Given this list of marker genes Slc5a5, Clca3b, Clcnkb, Ano8, Gabrd, Slc5a6, Gabrq, Apol10a (apolipoprotein L 10A), Chrm5, Slc25a25, Best3, Slc4a3, Slc26a10, Gabre, Clca3a1, Ano7 (NCBI Gene Id 404545), Mfsd5 (major facilitator superfamily domain containing 5), Gabrg2, Slc37a4, Gabrb1, Stx7, Clcn5, Slc6a18, Slc25a10, Slc4a10, Gabrr2, Slc22a3, Ttyh2, Slc1a7, Slc25a3, Gabra3, Ano4, Slc25a30, Slc4a1, Clic6, Glrb, Clic3, Cftr, Ano10, Slc26a1, Slc12a6, Gabrb3, Slc25a14, Best1, Slc12a7, Gabrg3, Trpv1, Slc12a4, Glra3, Ano9, Ano1, Slc4a5, Slc4a2, Cldn4, Slc6a6, Slc26a7, Gabrr1, Gabra4, Clic4, Slc26a9, Slc12a1 (solute carrier family 12, member 1), Tmc4, Gabrr3, Slc17a8, Slc25a27, Ano2, Chrna7, Vti1b, Slc26a8, Slc13a1, Slc6a13, Gabrp, Mfsd8, Gabrb2, Clca4a, Glra2, Slc37a1, Slc22a6, Vamp8, Slc25a24, Apol11a, Slc13a4, Slc17a1, Slc26a6, Slc1a4, Pacc1, Slc17a7, Clca3a2, Gabra2, Nherf1, Slc6a2, Stx1a, Clcn4, Slc4a4, Ano5, Ttyh1, Slc26a3, Ucp2, Ano6, Clca2, Apol8, Slc6a11, Slc12a3, Gabra6, Clcn3, Slc26a11, Slc4a11, Slc6a8 (solute carrier family 6 (neurotransmitter transporter, creatine), member 8), Nmur2 (NCBI Gene Id 216749), Slc6a12, Slc4a8, Slc34a1, Bsnd, Clic5, Slc25a23, Slc26a5, Slc34a2, Clcn2, Slc34a3, Aqp6, Stx8, Ttyh3, Clca4b, Gabra1, Slc22a8, Gabra5 (gamma-aminobutyric acid type A receptor subunit alpha 5), Apol9a, Abcc6, Slc12a9, Slc4a9, Glra1, Ano3 (anoctamin 3), Glra4, Slc20a2, Best2, Slc12a8, Clcn7, Slc20a1, Slc18a1, Apol11b, Slc17a6, Apol9b, Xpr1, Cldn17, Ank, Slc26a4, Apol10b, Slc4a7, Oca2, Slc22a1, Slc6a3 (solute carrier family 6 (neurotransmitter transporter, dopamine), member 3), Clic1, Clcn1, Slc37a2, Slc18a2, Slc12a5, Clcnka, Clcc1, Slc12a2, Slc1a1, Clca1, Clcn6, Slc26a2, Slc6a1, Slc6a4, Gabrg1, here is a description of the gene set: Mouse Gene Set: GOMF_INORGANIC_ANION_TRANSMEMBRANE_TRANSPORTER_ACTIVITY Enables the transfer of inorganic anions from one side of a membrane to the other. Inorganic anions are atoms or small molecules with a negative charge which do not contain carbon in covalent linkage. studied in species Mus musculus